The following is a description of a gene set: studied in species Homo sapiens p75NTR regulates axonogenesis Human Gene Set: REACTOME_P75NTR_REGULATES_AXONOGENESIS, and this is the list of marker genes: NGF, RTN4, NGFR, ARHGDIA, MAG, MCF2, RHOA, LINGO1, RTN4R, OMG